Given this list of marker genes IL18R1, LGALS9, IL33, IL27RA, PLA2G4A, IL1RL1, SLC11A1, CD80, CCR2, IL18, CCL19, IL1B, SOCS5, ASCL2, IL1R1, IL4R, SLAMF1, IL12B, TBX21, NLRP10, IL12RB1, IL23A, HAVCR2, ARID5A, TNFSF4, HLX, ANXA1, IL23R, XCL1, JAK3, IL27, RIPK2, here is a description of the gene set: Human Gene Set: GOBP_REGULATION_OF_T_HELPER_1_TYPE_IMMUNE_RESPONSE studied in species Homo sapiens Any process that modulates the frequency, rate, or extent of a T-helper 1 type immune response.